The following is a description of a gene set: studied in species Homo sapiens Human Gene Set: chr3q23, and this is the list of marker genes: RN7SKP25, RN7SKP124, GRK7, SPSB4, YWHAQP6, PHF5AP7, CLSTN2, TRPC1, RNF7, SLC25A36, COPB2-DT, LRRC78P, RPL19P6, CLSTN2-AS1, RNA5SP143, TRIM42, PLS1-AS1, PISRT1, MRPS22, RNU1-100P, HLMR1, PAQR9, KRT18P35, ENSG00000286988, COPB2 (COPI coat complex subunit beta 2), RNU7-47P, RBP2, PRR23B, RPL7L1P7, TFDP2, RNU6-509P, NMNAT3, PXYLP1, DTWD1P1, U2SURP, RNU6-1294P, ENSG00000286822, ACTG1P1, PAQR9-AS1, RPL8P3, XRN1, PRR23C, ENSG00000268129, HMGN2P25, ATR, RPL6P9, RASA2-IT1, ATP1B3-AS1 (ATP1B3 antisense RNA 1), PCOLCE2, TPT1P3, RBP1, EIF2AK1P1, RASA2 (NCBI Gene Id 5922), RPL31P21, BPESC1, RN7SL724P, TRMT112P5, ATP1B3, PLS1, PRR23A, RPL23AP41, ZBTB38, RNU6-425P, GK5